Given this list of marker genes FLT1, CARMIL2, STOX1, CORIN, IFNGR1, here is a description of the gene set: A recurrent infection of the GI tract with helicobacter pylori, a gram-negative, microaerophilic bacterium usually found in the stomach. species: Homo sapiens Human Gene Set: HP_HELICOBACTER_PYLORI_INFECTION Helicobacter pylori infection